Given this list of marker genes EGR1, HCG22, CXCL8, MARVELD3, DUSP1, RBP7, CALCR, LRRC8C-DT, UNC80 (NCBI Gene Id 84540), SNX29, TEX26, WFDC10B, ZDHHC1, APLF, RGR, LGI1, SMIM17, CXCL2, F3, FKTN, H2AP, HGFAC, ZFPM1, TNFAIP3, MAGI2-AS3, GREM1, STAP1, CD226, BIK (BCL2 interacting killer), C6orf52, CXCL3, CXCL1 (NCBI Gene Id 2919, C-X-C motif chemokine ligand 1), PAFAH1B2P2, CRYBG2, CCNP, KCNF1, UCN3, SLFNL1-AS1, LINC00635, TMEM9B, OR6A2, SLC30A8, GPR4, CLEC4C, TLL1, GABRA5, SHISAL2A, CYP11A1, IER3, SPINT1, P2RY10, NFKB2, UFSP1, ST3GAL2, ELSPBP1 (epididymal sperm binding protein 1), PTX3, FRG2EP, SLC39A5, MPP3, NFKBIZ, KLK10, TSSK6, SBSPON, TCF12-DT, ANKDD1A, TRIM29, TMEM30A, CCL20, IQCG, RGS6, LDLRAD4, CHRNA1, BTG2, SLC24A4, MRAP2, LINC02003, MMAA, IFI44, MANF (NCBI Gene Id 7873), CD4, GMNC, CCL2, SLC7A7, PRDM9, HORMAD1, ABCC12, MEI1, SLC25A31, SRRM2-AS1, SDC4, XYLB, TAS2R8, H2BC1, SLC18A3, C2orf72, GAN, ODAD1, UBE2NL, LSMEM2, CREB5, NKAPP1, ATOH1, FGF5, TNFSF15, LINC02946, DUOXA1, NHEG1 (NCBI Gene Id 100294720), TMEM127, POU2F3, PIWIL2, CST11, BICC1, ZNF415, PLPP4, CD82, ERP27, CELSR3, MAP3K8, PRLR, BHLHE22, NUTM2F, ST6GAL2, ZNF705G, ARMCX4 (armadillo repeat containing X-linked 4), ZNF252P-AS1, CRYBA1, DUOX1, IRF8, TIFA, POU2AF2, ARAP3, TBC1D9, DNASE1L3, ENSG00000293232, SLC25A43, GARIN3, LSAMP-AS1, OR51B6, RAB9B, PYROXD1, MYBPC1, VMP1, ENSG00000228919, CSRNP1, CMA1, ENSG00000280119, MIR4500HG, NFKBIA, JUN, TNFRSF9, MMP27, AK9, LINC03066, TMOD4, WDR27, ATF3, LINC00960, TREM2, NEXMIF, DELE1, CRNN, PTGS2, CYP4F2, PIP5KL1, AGTR1, PADI4, IPCEF1, GPR21, LINC01010, OTUD1, LINC00668, EHBP1L1, TRBC1, IKZF1, CHRNB2, VIL1, CD84, ADAM21, RIN1, KRT76, MIR3936HG, BRD7P3, AHI1, GARIN5A, MUC7, IQUB, TNFRSF14-AS1, PLA2G15, SLC16A9, LINC00410, PPP1R15B, here is a description of the gene set: species: Homo sapiens Human Gene Set: GSE45365_CD8A_DC_VS_CD11B_DC_IFNAR_KO_MCMV_INFECTION_DN Genes down-regulated during primary acute viral infection in dendritic cells: CD8A versus ITGAM+. Murine Cytomegalovirus (MCMV) infection leads to early activation of various immune cells, including B and T lymphocytes, before the actual initiation of antigen-specific adaptive immunity. This activation is partly driven by innate cytokines, including type I interferon (IFN), which are induced early after infection. The objective of this study was to address the role of type I IFN in shaping early/innate B and T cell responses to a primary acute viral infection. In order to decipher the specific impact of IFN-I on cell subsets, we performed a genome-wide expression analysis on WT splenic B and CD8 T lymphocytes isolated from C57BL/6 mixed bone marrow chimera mice. This study complements series GSE39555, which focused on early responses of NK cells and of the two subsets of conventional dendritic cells.